The following is a description of a gene set: Binding to an interleukin-2 receptor. Human Gene Set: GOMF_INTERLEUKIN_2_RECEPTOR_BINDING species: Homo sapiens, and this is the list of marker genes: TIMM50, GATA3, ECM1, IL21, IL2 (interleukin 2)